Given this list of marker genes Acsl1, Slc27a1, Acsf3, Slc27a6, Acsm2, Acsl6, Dip2a, Sucla2, Aacs, Acsl5, Acsbg3, Acsl3, Acsbg2, Acsm3, Acsm1, Aasdh, Slc27a2, Acss2, Acsm5, Slc27a4, Slc27a5, Slc27a3, Acsl4, Acsbg1, Acsf2, Acsm4, Acss1, Suclg1, Acss3, Suclg2 (NCBI Gene Id 28021), here is a description of the gene set: species: Mus musculus Catalysis of the joining of an acid and a thiol via a carbon-sulfur bond, with the concomitant hydrolysis of the diphosphate bond in ATP or a similar triphosphate. Mouse Gene Set: GOMF_ACID_THIOL_LIGASE_ACTIVITY